Given this list of marker genes MEGF8, FIG4, ATP6V1B2, LMNA, IFT140, NSDHL, FGFR2, GJA1, here is a description of the gene set: Aplasia of the middle phalanx of the hand Absence of one or more middle phalanx of a finger. Human Gene Set: HP_APLASIA_OF_THE_MIDDLE_PHALANX_OF_THE_HAND studied in species Homo sapiens